Given this list of marker genes CFP, CFD, C3, CFB, GZMM (granzyme M), here is a description of the gene set: studied in species Homo sapiens Human Gene Set: REACTOME_ALTERNATIVE_COMPLEMENT_ACTIVATION Alternative complement activation